Given this list of marker genes Irgm1, Tom1, Igtp, Smcr8, Calcoco2, Clec16a, Fyco1, Adrb2, Irgm2, here is a description of the gene set: Mouse Gene Set: GOBP_POSITIVE_REGULATION_OF_AUTOPHAGOSOME_MATURATION studied in species Mus musculus Any process that activates or increases the frequency, rate or extent of autophagosome maturation.